Given this list of marker genes HLA-DRA, HCST (hematopoietic cell signal transducer), CYTOR, DNAJB1, HLA-DMA, LAG3, XCL2, PTPRC, CD27, CLDND1, CLEC2B, GIMAP7, DENND2D, SLAMF7 (SLAM family member 7), CST7, LIME1, GZMK, PRF1, KLF2, TIGIT, PLEK, LINC00861, CD8A, PLAAT4, HLA-DRB5, PLAAT3, CCL5, AHNAK, APOBEC3C, GZMA, HLA-A, CNN2, NFATC2, IKZF3, BTN3A2, GZMM, NKG7, APOBEC3G, CD8B, HLA-DRB1, CD74, CCL4L2, IFNG, ITGB2, F2R, ARPC5L, TOX (thymocyte selection associated high mobility group box), HLA-DPB1, CCL4, APMAP, AOAH, CXCR4, FABP5, GZMH, C12orf75, KLRG1, HLA-B, CMC1, CYBA, CRTAM, PTPRCAP, PDCD1, STK17A, LITAF, HLA-DPA1, MT2A, SAMD3, DUSP2, PSMB9, CCL3, HLA-DQB1, LYAR, HLA-F, LYST, OPTN, CD99, CTSW, CTSC, TNFSF9, SH2D1A (NCBI Gene Id 4068), EOMES, HLA-DQA1, HLA-C, PYHIN1, TAGAP, GIMAP4, CXCR3, TPST2 (tyrosylprotein sulfotransferase 2), DGKZ, ITM2C, NUCB2, here is a description of the gene set: from publication Jiang C, Chao CC, Li J, Ge X, Shen A, Jucaud V, Cheng C, Shen X (PMID 38455971) Tissue-resident memory T cells (TRM) are a specialized T cell population residing in peripheral tissues. The presence and potential impact of TRM in the tumor immune microenvironment (TIME) remain to be elucidated. Here, we systematically investigated the relationship between TRM and melanoma TIME based on multiple clinical single-cell RNA-seq datasets and developed signatures indicative of TRM infiltration. TRM infiltration is associated with longer overall survival and abundance of T cells, NK cells, M1 macrophages, and memory B cells in the TIME. A 22-gene TRM derived risk score was further developed to effectively classify patients into low- and high-risk categories, distinguishing overall survival and immune activation, particularly in T cell-mediated responses. Altogether, our analysis suggests that TRM abundance is associated with melanoma TIME activation and patient survival, and the TRM-based machine learning model can potentially predict prognosis in melanoma patients. Human Gene Set: JIANG_MELANOMA_TRM10_LAMINA_PROPRIA studied in species Homo sapiens